The following is a description of a gene set: Genes having at least one occurence of the motif CAGTCAC in their 3' untranslated region. The motif represents putative target (that is, seed match) of human mature miRNA hsa-miR-134 (v7.1 miRBase). Human Gene Set: CAGTCAC_MIR134 studied in species Homo sapiens, and this is the list of marker genes: EPHA7, CSNK1G3, ZDHHC9, KAT7, COL2A1, ZFPM2, MED13, CELF2, C6orf120, SERTAD2, ILDR2, TRMT11, PPP1R12A, ADGRL3, VGLL4, ACSL1, ZNF711, BANF1, PPP1R7, TSC22D1, MAGIX, GNAO1, SMARCAD1, ASIC1, HIC2, PATZ1, CDH9, MAT2A, UBAP2, TAPBP, C1orf21, AFF3, EIF3J, ETF1, KPNA3, MTCL1, MBNL1, TTBK1 (tau tubulin kinase 1), APBB3 (NCBI Gene Id 10307), SRSF2, STRBP, SRSF8 (serine and arginine rich splicing factor 8), PSD3, SMAD6, SYNM, OPCML, SLC25A5, MYCN, FAM91A1, CPEB2, VEGFA, NRF1